The following is a description of a gene set: studied in species Mus musculus Mouse Gene Set: WP_EGFR1_SIGNALING_PATHWAY EGFR1 signaling pathway, and this is the list of marker genes: Mapk8, Egf, Tgif1, Elk4, Src, Eps8, Sh3gl3, Pik3r1, Socs3, Jund, Mcf2, Eps15l1, Pik3r3, Plscr1, Cav2, Krt17, Zpr1, Htt, Map3k1, Rps6ka2, Wasl, Ptprr, H3f4, Reps2, Mta2, Tnk2, Jak2, Krt7, Map2k2, Egfr, Elk1, Cblb, Ceacam1, Wnk1, Myc, Ptpn5, Rps6ka5, Dok2, Casp9, Nras, Elf3, Sos2, Git1, Hat1, Ptk6, Spry2, Cav1, Jun, Ralgds, Mapk7, Sp1, Plcg2, Sin3a, Rfxank (regulatory factor X-associated ankyrin-containing protein), Plec, Cbl (NCBI Gene Id 12402), Tnip1, Ywhab, Stxbp1, Pld1, Camk2a, Sos1, Krt8, Vav1, Pkn2, Cebpb, Ptpn12, Reps1, Mapk1, Sh3kbp1, Araf, Prkcz, Rac1, Hip1, Rasa1, Map3k2, Epn1, Rps6ka1, Rbbp7, Pak1, Appl1, Map3k4, Pik3c2b, Foxo1, Ralb, Ap2a1, Abi1, Asap1, Socs1, Nck2 (non-catalytic region of tyrosine kinase adaptor protein 2), Shc1, Cdc42, Pik3cd, Creb1, Grb14, Grb7, Prkca, Fos, Prkci, Atf1, Stat5b, Sh2d3c, Cblc, Map2k7, Rab5a, Rgs16, Smad2, Gab1, Ralbp1, Arf4, Hdac1, Ctnnd1 (NCBI Gene Id 99192), Dnm1, Sh3bgrl, Gab2, Stat2, Itch, Pxn, Ptk2b, Prkd1, Krt18, Vav3, Nck1, Akt1, Mapk3 (NCBI Gene Id 26417), Snca, Jak1, Stat3, Sh3gl2, Pld2, Crkl, Klf11, Raf1, Map2k5, Map3k3, Prkcb, Stat5a, Errfi1, Crk, Pik3cb, Plcg1, Map2k3, Eef1a1, Map2k1, Rps6ka3, Kras, Mapk14, Grb2, Ndufa13, Ptpn11, Eps15, Csk (NCBI Gene Id 12988), Snrpd2, Pitpna, Smad3, Grb10, Inppl1, Dusp1, Stat1, Pik3cg, Ptpn6, Vav2, Map3k14, Appl2, Shoc2, Bcar1, Ripk1, Prkar1a, Pebp1, Usp6nl, Hras, Gja1, Pik3r2, Cebpa, Pik3ca